Given this list of marker genes P2rx3, Drd2, Dlg1, P2rx2, Tbx2, Tbx3, Npy1r (neuropeptide Y receptor Y1), Agt, Gdnf, Neurog1, Tifab, Tshz3, Drd1, Sstr2, here is a description of the gene set: species: Mus musculus A wavelike sequence of involuntary muscular contraction and relaxation that passes along a tubelike structure, such as the intestine, impelling the contents onwards. Mouse Gene Set: GOBP_PERISTALSIS